Given this list of marker genes POLG, KCNC3, GBA2, ITPR1, RRM2B, SLC20A2, DAB1, WASHC5, PDGFRB, ZFHX3, PDGFB, GRM1, NF1, PPP2R2B, RNASEH1, CYP7B1, here is a description of the gene set: Limb dysmetria Human Gene Set: HP_LIMB_DYSMETRIA species: Homo sapiens A type of dysmetria involving the limbs.